The following is a description of a gene set: from publication El Kasmi KC, Holst J, Coffre M, Mielke L, de Pauw A, Lhocine N, Smith AM, Rutschman R, Kaushal D, Shen Y, Suda T, Donnelly RP, Myers MG Jr, Alexander W, Vignali DA, Watowich SS, Ernst M, Hilton DJ, Murray PJ (PMID 17114459) Genes up-regulated in bone marrow-derived macrophages (45 min): IL10 and LPS versus IL6 and LPS. species: Homo sapiens Human Gene Set: GSE5589_LPS_AND_IL10_VS_LPS_AND_IL6_STIM_MACROPHAGE_45MIN_UP IL-10 or IL-6 stimulation of control 129xC57BL/6 murine bone marrow derived macrophages in the presence of LPS. We used microarrays to detail the global programme of gene expression changes in response to IL-6 or IL-10 stimulation in the presence of lipopolysaccharide. BMDMs were isolated from control, IL-6-/-, and IL-10-/- mice on a 129XBL/6 mixed background mice and differentiated in the presence of CSF-1 for 6-7 days. Cells were scraped and plated in 6 well plates at 2x10e6/well. Cells were washed with complete DMEM and rested for 1-2 hr before stimulation with combinations of IL-10 (10 ng/ml), IL-6 (2 ng/ml) or LPS (100 ng/ml) for 45 min or 180 mins. Complete biological replicates were performed., and this is the list of marker genes: CYP27A1, C1orf216, DALRD3, ATP2B1, TOM1, TRIM65, PPOX, PRKCI, VPS33B, TM2D2, PACRG, BBS7, GATC, SETX, IRGQ, STOM, TRPM7, SLC25A39, KBTBD13, APRT, CRTAP, HCFC1R1, TMEM183A, UNC93B1, WDR5B, NF1, TCF4, ADGB, HEATR5B, PEX7, FBXW4 (NCBI Gene Id 6468), SQOR, PKD1, ERBIN, TTC38, ZDHHC20, SDHAF4, ERI3, CIBAR1, TWNK, GDPD3, ZFAND1, KIAA0753, CDKN1B, CEP131, GINM1, CDC42BPB, PRRG1, KLHDC10, TCF12, OLFML3, CGRRF1, NENF, RELL1, DOCK4 (dedicator of cytokinesis 4), PIP4K2A, MOK, ATG2A, TBC1D10A, SPA17, BCAS3, BEX1, PIAS3, PTPRS, CALCOCO1, RIDA, APPL2, TF, PEX5, DIP2B, KBTBD2, MAN1C1, CDKL2, TMED1, IKBKG, ALDOC, FMO5, GPS2, WDR45, PIR, SQLE, CTSB, ZNF746, PIKFYVE, FOXN3, C3orf33, NEU1, FUCA1, CD99L2, SMAP1, TRAM1, ACADS, PPP1R3B, DAND5, RNF144B, WDR26, GALNT4, SPG11, C15orf61, PAQR3 (progestin and adipoQ receptor family member 3), PRDX2, RNF149, NAT9, SLC25A1, PTS, CXorf38, TPCN1, RNF180 (NCBI Gene Id 285671), ZFAND2A, BLOC1S3, TMEM205, AFF4, OXSM, FAM210A, ABCD1, RNF103, GSTM5, RXRB, ANKRD28, RNF166, BAHD1, MCEE, PHF1, TEX264, FBXL20, GTF3C1, HYAL2, LRRC57, PEPD, TM6SF1, PANK1, SECISBP2L, LDAF1, TRMT1, TMEM37, P2RY6, PACS2, HPS4, MZT2B, SLC25A46, AIFM2, TMCO3, GLIS3, INVS, SNAP47, SORBS3, NKIRAS2, ARHGAP23, ASXL2, ASL, GPHN, TRAPPC13, IRAK4, ETV1, SPATA6, RCBTB2 (NCBI Gene Id 1102), KPNA6 (NCBI Gene Id 23633), C1orf198, SNX33, AGO3, C7orf50, FIG4, EIF2AK4, ATP6V1E1, SPTAN1, TGFBR2, TPK1, MTMR10, ABCC1, ATMIN, CNOT8, CBY1, DCTPP1, NFIC, EEF2, CDS1, TFDP2, RNLS, TRAPPC10, KRT10, MRPS15, NHSL3 (NHS like 3), RWDD2A, SLC2A12, TMX4, P3H3, DENND4C, CYTH3, RASSF3, ARHGAP31, FOXO3, LRSAM1, SAMD4B, QKI, MAGEE1, CUL7, MCRIP2, PGAP1, MTFR1L, ATG101